The following is a description of a gene set: studied in species Mus musculus Any process that activates or increases the frequency, rate or extent of oligodendrocyte differentiation. Mouse Gene Set: GOBP_POSITIVE_REGULATION_OF_OLIGODENDROCYTE_DIFFERENTIATION, and this is the list of marker genes: Ptprz1, Il33, Rheb, Qki, Nkx6-1, Hdac2, Tlr2, Tenm4, Trp73, Dag1, Ptn, Il34, Mtor, Mir219a-1, Cxcr4, Clcn2, Nkx6-2, Tnfrsf1b, Zfp365, Enpp2, Myrf, Shh, Mir23a, Mdk, Zfp488, Prmt5, Pparg, Mir219a-2, Nkx2-2, Nkx2-2os, Olig2, Hdac1, Aspa, Ptpra, Gsx2